Given this list of marker genes PML, RTP4, SERPINB9, PAK6, FHDC1, HASPIN, DCLK1, BRI3BP, C15orf40, DHDH, MATK, RRP7A, NUP93, QNG1, FAM81A, SMPDL3A, RNMT, PDCD1, TCEAL9, EMC10, NF2, VCAN, B9D1, GUSB, MXD3, IL18R1, ADPRM, ANXA4, GAS2L1, PTPN12, POMP, LGALS9B, ACTN4, TMEM167A, EXOC4, GTSE1, MMD, TMEM140, PYGO2, MELK, NCAPD2, MIS18BP1, CMSS1, RGS10, RAD51AP1, RAB8B, TEX9, APOO, RUNX2, LGALS3BP, HIC1, UBE2C, BRIP1 (NCBI Gene Id 83991), KCTD5, AP1S3, ENKD1, LIF, MSTO1, ATP2A2, AP1S2, STON2, SERHL2, ENSG00000286190, BUB1B, RDH11, MCM8, CARNMT1, HADHA, TPX2, PXMP2, PIK3AP1, CDC45, SKA1, POPDC2, CENPK, LYPLA1, LIME1, AUNIP, RIDA, IRF4, PLCB1, GZMK, COBLL1, NFIL3, CCR5, BORA, EXO1 (exonuclease 1), PEAR1, AHCY, PPP3CC, AFTPH, FGR, ABHD4, RDM1, ASF1B, NEK7, MND1, NFATC1, PRC1, PRRT4, TMEM106A, CENPH, MLKL, ARHGAP26, LPGAT1, GLMP, ERCC2, ECI2, SSR1, NIBAN1, CCDC92, FAM177A1 (NCBI Gene Id 283635), MYADM, ADPRH, DHRS1, ARHGAP19, CCAR1, SLC37A4, MAP2K4, ADAP1, UBXN8, BCAT1, ARPC1A, OPN3, ZFAND4, ALAD, ATP8B2 (ATPase phospholipid transporting 8B2), DHX58, MAP2K3, RNH1, CLSTN1, KIF20A, TTF2, TXNDC17, JAK3, SPC25, NEK4, CREB3L1, PAFAH1B3, TRAIP, RNF216, ATP5PF, FHL2, TUBB3, KNSTRN, PIF1, SAPCD2, NFATC2, ABCB9, CCNF, VSIG10, FLAD1, VDAC3 (voltage dependent anion channel 3), PERP, C6orf58, ATG7, NGLY1, UQCRQ, PSMA2, ZNF410, METRNL, FRMD4B, VPS26C, MRPL34, LDHA, SEC61B, ATF6, RORA, SCCPDH, GPR155, DNA2, PLEKHB2 (pleckstrin homology domain containing B2), AP5Z1, DTL, TRMT1L, SPC24 (SPC24 component of NDC80 kinetochore complex), POLQ, CBX5, TMEM184B, SRI, HMCES, ARPC1B, XAF1, MRPL38, DYNLT1, EFHD2, CFAP157, PLAGL1, UBXN2B, OPTN, COX6B1, ROPN1L, UTP11, CYP11A1, IL12RB2, SHCBP1, PDCD6IP, RAB39B, CARHSP1, PAQR4, here is a description of the gene set: Genes up-regulated in CXCR5+ BCL6+ follicular helper T cells versus CXCR5+ BCL6- CD4+ T cells. T follicular helper (Tfh) cells play a pivotal role in germinal center reactions, which requires Bcl6 transcription factor. To analyze their relationships with other effector T cell lineages and their stability in vivo, we developed and analyzed a new Bcl6 reporter mouse alone or together with other lineage reporter systems. Assisted with genome-wide transcriptome analysis, we show substantial plasticity of T cell differentiation in the early phase of immune response. At this stage, CXCR5 appears to be expressed in a Bcl6-independent manner. Once Bcl6 is highly expressed, Tfh cells can persist in vivo and some of them develop into memory cells. Together, our results indicate Bcl6 as a bona fide marker for Tfh polarized program. studied in species Homo sapiens Human Gene Set: GSE40068_BCL6_POS_VS_NEG_CXCR5_POS_TFH_UP from publication Liu X, Yan X, Zhong B, Nurieva RI, Wang A, Wang X, Martin-Orozco N, Wang Y, Chang SH, Esplugues E, Flavell RA, Tian Q, Dong C (PMID 22987803)